Given this list of marker genes Il1a, Tmem131l, Blm, Wnt4, Erbb2, Bmi1, Foxp3, Il1b, Gnrh1, Tnfrsf9, Shh, Cd1d1, Tnfsf9, Ihh, Cdkn2a, Ripk2, Clec4g, Ifnar2, Bmp4, here is a description of the gene set: The expansion of an immature T cell population by cell division. studied in species Mus musculus Mouse Gene Set: GOBP_IMMATURE_T_CELL_PROLIFERATION